The following is a description of a gene set: studied in species Mus musculus Mouse Gene Set: chr15D3, and this is the list of marker genes: Ly6c2, Adgrb1, Gm24787, Zfp707, Oplah, Foxh1, Mafa, Cyc1, Gm35933, Ly6g2 (NCBI Gene Id 223631), Rpl8, Gsdmd, Naprt, Iqank1, Fbxl6, Gpihbp1 (NCBI Gene Id 68453), Ccdc166, Dennd3, Gm49415, 5730521K06Rik, Gm41349, Mirt2, Slc39a4, Ly6l, Ly6a, Gm22106, Gm19811, 1700085D07Rik, Ly6e, 4833412C15Rik, Gm24232, 4933427E11Rik, Gml, Slc45a4, Ndufb4c, Ly6h, Ptp4a3, Grina, Recql4, Gm10362, Gm18930, Hgh1, Hsf1, Mir3079, Gm34646 (NCBI Gene Id 102637965), Spatc1, Gm2999, Adck5, Zfp41, 4930504C09Rik, Gm17271, Sharpin, 1110038F14Rik, Ly6g, Lypd2, Gm6569, Gm15387, Gm10238, Gm28020, Apol7a, Wdr97, Gm18283, 4930573C08Rik, Parp10, Gm3150, Vps28, Apol6, Gm3787, Rps6-ps1, 1700010B13Rik, Gm5216, BC024139, Gm46519, Mir6952, Gm18155, Tmem249, Mapk15, Eif2s3x-ps1, Gm23747, Nrbp2, Gpt, Mir1942, Ly6a2, Kcnk9, Ly6f, Slurp1, Gm19945, Mroh6, Gfus, Dgat1, Gm19782, Gm22519, Scrt1, Tigd5, Gm3142 (predicted gene 3142), Ly6m, Slurp2, Kifc2, Fam135b, Ly6k, Zc3h3 (NCBI Gene Id 245129), Smpd5, Gm7908, Khdrbs3, Gm34593, Gm39556, Mroh4, Arhgap39, C030006K11Rik, Top1mt, Pycr3, Bop1, Plec, Gm41341, Gm8000, Rhpn1, Apol9a, Eef1d, Lrrc24, Gm23987, Tonsl, Ago2, Zfp647, Gm28114, Gml2, Zfp7, Tssk5, 4930571N24Rik, Mir6953, Gm6610, Apol7b, Chrac1, Cyp11b2 (NCBI Gene Id 13072), Cyp11b1, Mir6954, 2810039B14Rik, Gm9568, Gm5960, Zfp251, Gpr20, Ptk2, Lynx1, Trappc9, Peg13, Maf1, Scx, Gm28068, Ly6d, Gm7935, Col22a1, Gm48952, Ly6i, Fam83h, Mroh1, Ly6g6g, Jrk, Mfsd3, Mb, Zfp623, Gm32405, Ppp1r16a, Gm24056, 1700109K24Rik, Arc, Gm3454, Gm5217, Scrib, Gm28117 (NCBI Gene Id 108168217), Exosc4, Rbfox2, Lrrc14, Mroh5, Commd5, Puf60, Them6, Gpaa1, Gm19199, 9030619P08Rik, Mir151, Zftraf1, Cpsf1, Gm16308, Psca, Ly6c1, Gm49436, Slc52a2, Gm6506